Given this list of marker genes ACAT2, PITRM1, COX16, MT-TF, MT-TI, UQCRC2, MPC1, NDUFA6, NDUFAF4, NDUFS7, NDUFS8, COX10, NDUFB3, POLG, NDUFAF1, AIFM1, NDUFB11, MT-ND1, SCO2, NDUFA1, MT-TL1, PNPLA8, MT-ND2, NDUFB10, TMEM126B, NDUFAF5, NDUFV1, LIPT2, NDUFAF8, NDUFAF2, DLD, LONP1, MECP2, FOXRED1, NDUFA11, MPV17, TWNK, NDUFV2, SDHB, KARS1, MT-ND3, NDUFS4, PDHX, PC, COX6A2, MT-TP, NDUFAF3, NDUFS6, NUBPL, NDUFB9, SLC25A26, TIMMDC1, NDUFS2, NDUFS3, PDHA1, LDHA, NDUFS1, MT-TK, BCS1L, here is a description of the gene set: studied in species Homo sapiens Increased circulating pyruvate concentration Human Gene Set: HP_INCREASED_CIRCULATING_PYRUVATE_CONCENTRATION The concentration of pyruvate in the blood circulation is above the upper limit of normal.